Given this list of marker genes HOOK3, SEPTIN14, HOOK1, AKTIP, FHIP1B, HOOK2, RNF26, FHIP1A, SQSTM1, here is a description of the gene set: Human Gene Set: GOBP_PROTEIN_LOCALIZATION_TO_PERINUCLEAR_REGION_OF_CYTOPLASM A process in which a protein is transported to, or maintained in, a location within the perinuclear region of the cytoplasm. studied in species Homo sapiens